The following is a description of a gene set: studied in species Homo sapiens The directed movement of a C4-dicarboxylate into, out of or within a cell, or between cells, by means of some agent such as a transporter or pore. A C4-dicarboxylate is the anion of a dicarboxylic acid that contains four carbon atoms. Human Gene Set: GOBP_C4_DICARBOXYLATE_TRANSPORT, and this is the list of marker genes: ABAT, SLC1A1, SLC1A2, SLC1A6, SLC25A10, SLC25A18, SLC25A13, UCP2, SLC16A1, SLC1A5, SLC25A22 (NCBI Gene Id 79751), LRRC8B, SLC13A3, LRRC8D, NTSR1, GFAP, SLC1A3, SLC13A2 (solute carrier family 13 member 2), LRRC8C, SLC7A13, SLC25A11, LRRC8A, SLC12A2, LRRC8E, SLC1A4, SLC13A5, SLC25A12, SLC3A1